Given this list of marker genes Aldh3a2, Kbtbd8, Tifa, Tpp1, Htr5b (5-hydroxytryptamine (serotonin) receptor 5B), Mrgprx2, Rbbp8, Sobp, Vipr2, Gtf2h1, Tspan32, Pdcd1lg2, Ccdc97, Gpatch8 (G patch domain containing 8), Dazap2, Retreg3, Mlec, Lamc1, Zfp616 (zinc finger protein 616), Nav1, Fgf14, Clec4a1, Lrch2, Zfp704, Vmn2r81, Cep72, Lyplal1, Elp1, Hapstr1, Prkg1, Psme4, Pcdh9, Cables2, Bpifa1, Man1a2, Glt8d2 (NCBI Gene Id 74782), Gja4 (NCBI Gene Id 14612), Kpna1, Lrp2bp, Ildr2, Xpot, Gtpbp1 (GTP binding protein 1), Dynlt3, here is a description of the gene set: studied in species Mus musculus Mouse Gene Set: MIR_1967 from publication Chen Y, Wang X (PMID 31504780) Genes predicted to be targets of miRBase v22 microRNA mmu_miR_1967 in miRDB v6.0 with MirTarget v4 prediction scores > 80 (high confidence targets).